Given this list of marker genes CDK2 (NCBI Gene Id 1017), RAD51, CCNA2, SMARCAL1, FBXW11, TOPBP1, PLK1, MCM2, CHEK1, RPA1, PPP2R2B, TIMELESS, TIPIN, CDC25C (NCBI Gene Id 995), PPP2R1A, PPP2CA, RAD17, HUS1, RFC5, CLSPN, ATRIP, BRCA2, YWHAZ, RAD1, RFC4, RPA2, YWHAB, MDM2, CDC6, MCM7, NBN, SSPOP, FANCD2, RFC3, CEP164, ATR, CDC25A, RAD9A, RFC2, here is a description of the gene set: ATR signaling pathway Human Gene Set: PID_ATR_PATHWAY species: Homo sapiens from publication Schaefer CF, Anthony K, Krupa S, Buchoff J, Day M, Hannay T, Buetow KH (PMID 18832364)